Given this list of marker genes CXCL8, F7, GDNF, PLXNB3, PDGFB, DEFB110, SCG2, CCL16, DEFB104B, COLEC10, CXCL10, HGF, AZU1, TSC2, IL16, CCL5 (C-C motif chemokine ligand 5), DEFB114, SCRIB, VEGFB, CASR, CXCL12, SEMA5A, DEFB130A, CCL15, VEGFC, DEFB104A, LGALS3, CDH13, FPR2, ITGA2, DEFB103B, FGF2, HMGB2, APP, VEGFA, SMAD3, DEFB4A, AGER, DEFB103A, PTPRJ, MET, CX3CL1, GPNMB, NTF3, WNT7B, ARTN, S1PR1, ANGPT1, VEGFD, PGF, CCL2, DEFB109B, WNT5A, NRP1, FGF8, ALKBH1, F2RL1, CREB3, BMP4, DEFB133, FGF10, CORO1A, F3, NTRK3, CCL3, DEFB130B, FGF7 (NCBI Gene Id 82955), MIF, ANGPT2, HMGB1, KDR, S100A4, here is a description of the gene set: Human Gene Set: GOBP_POSITIVE_CHEMOTAXIS The directed movement of a motile cell or organism towards a higher concentration of a chemical. species: Homo sapiens